Given this list of marker genes TMEM201, CDK19, UBL4A, PPP1R9B, CLRN1, SHISA7, ECEL1, INHBC, DHRS9, NCOA5, KIR2DL3, CAMK2G, VPS26B, TANC2, CERKL, IMPA1, SHISAL1, SH3PXD2A, STMN4, RANGRF, SIK3, KIR2DL4, EXOSC2, EPB41L1, KCTD15, SMARCD2, NTRK2, SHISA6, POU2F2, KIR2DL1, SCN3A, PEG10, DIP2C, AKNA, IQSEC3, TBC1D5, TP53INP2, ATP11B, TRAM1, CHRFAM7A, MALL (NCBI Gene Id 7851), NRGN, SLC1A7, WDR91, EGR3, AMER2, ITK, NDST1, ZFP41, KIR3DL3, MSX1 (msh homeobox 1), PHKA1, here is a description of the gene set: studied in species Homo sapiens Genes predicted to be targets of miRBase v22 microRNA hsa-miR-3144-5p in miRDB v6.0 with MirTarget v4 prediction scores > 80 (high confidence targets). from publication Chen Y, Wang X (PMID 31504780) Human Gene Set: MIR3144_5P